Given this list of marker genes HIF1A, JMJD6, DDIT3, MBTPS2, STK3, NOTCH1, BICRA, NSD3, PARP1, ELK1, SAV1, here is a description of the gene set: studied in species Homo sapiens A molecular function regulator that increases the activity of a transcription regulator via direct binding and/or post-translational modification. Human Gene Set: GOMF_TRANSCRIPTION_REGULATOR_ACTIVATOR_ACTIVITY